The following is a description of a gene set: Combining with insulin receptor ligand and transmitting the signal across the plasma membrane to initiate a change in cell activity. species: Mus musculus Mouse Gene Set: GOMF_INSULIN_RECEPTOR_ACTIVITY, and this is the list of marker genes: Met, Ntrk1, Mup4, Mup11, Insrr, Mup3 (NCBI Gene Id 17842), Flt1, Alk, Fgfr1, Ret, Epha1, Kdr, Ntrk3, Epha2, Epha7, Ror2, Tyro3, Epha3, Pdgfra, Musk, Ltk, Kit, Egfr, Flt3, Flt4, Csf1r, Ddr2, Igf1r, Axl, Ephb4, Epha6, Pdgfrb, Mertk, Erbb2, Tie1, Mup1, Tek, Fgfr4, Ephb2 (NCBI Gene Id 13844), Epha5, Insr, Epha8, Ros1, Epha4, Mup5, Ephb1, Ntrk2 (neurotrophic tyrosine kinase, receptor, type 2), Erbb4, Ephb3, Epha10, Fgfr3, Ddr1, Mup2 (major urinary protein 2), Fgfr2, Mst1r